The following is a description of a gene set: studied in species Homo sapiens Human Gene Set: TRAVAGLINI_LUNG_CAPILLARY_INTERMEDIATE_2_CELL from publication Travaglini KJ, Nabhan AN, Penland L, Sinha R, Gillich A, Sit RV, Chang S, Conley SD, Mori Y, Seita J, Berry GJ, Shrager JB, Metzger RJ, Kuo CS, Neff N, Weissman IL, Quake SR, Krasnow MA (PMID 33208946), and this is the list of marker genes: DAZAP2, BBLN, PTMS, ATP5PD, CCNI, CCDC25, SERPINB6, GBP3, TMEM219, POMP (NCBI Gene Id 51371), WDR45B, SUMO3, GMFG, RFLNB, RHOA, S100A6, IFI27L2, GPIHBP1, MT1M, GABARAP, CAPN2, SH3BP5, HLA-DQA1, UBA52, S100A10 (S100 calcium binding protein A10), PCNP, SYNJ2BP, PSIP1, RBX1, ARHGEF12, FKBP8, FAM204A, S100A13, FAM107A (family with sequence similarity 107 member A), SSU72, MT1E, CETN2, BAG1, IFI27, JCAD, SAP18, RPL27, AP3S1, NUCB2, UBE2L6, MRFAP1, NHERF2, SERINC1, MAFF, RWDD1, POLR2L, PCAT19, CCL20, ARL2 (ADP ribosylation factor like GTPase 2), IFITM3, NDUFA4, CCDC69, SLC14A1, PDAP1, HLA-DPB1, ARHGAP18, PDLIM2, TMEM126B (NCBI Gene Id 95018), RALA, C7orf50, RGCC, SLU7 (NCBI Gene Id 10569), PAK4, NDUFA13, PTP4A3, NDUFS5, MOCS2, RBM17, TRIR, TLE5, MRPS18B, RPS24, RPL27A, SNX5, FBXO21, PCTP, POLR3GL, R3HCC1, C1orf115, C4orf3, RPLP2, SPOP (NCBI Gene Id 8405), GOLGA4, RPL38, LSM3, ATRX, GIMAP6, ZBTB8OS, NDRG2, CARINH, MT2A (NCBI Gene Id 4502), GPX1, VAMP5, EI24, SET, ANAPC16, SNHG6, KIF1C, NDUFB4, UQCR11, RPS27L, HSBP1, HSPA12B, SH3BGRL, HNRNPM, SUMO2, MTIF3, MBP, TPM1, VAMP3, COX7C, SEC62, KLHL5, YBX1, ARRDC2, IL7R, OPTN, RAP1A, EGFL7, ISCU, HMGB1, SCGB3A1 (NCBI Gene Id 92304), SRP9, RPL37, DPYSL3, AKR1C3, GPX4, CARD16, ZC3H13, TMA7, RPS20, MYL6, FIS1, RPS27A, YWHAE, ZEB1, COX6C, BTN3A1, ATP5IF1, RPS4Y1, FTL, COPS9, RPS28, OST4, IFI6, OTUD6B-AS1, MT1L, ANP32B, POLR2F, SLIRP, SNRPD2, MAP4, MED28, S100A3, NAP1L1, CAVIN1, TTC1, SVIP, CDC26, STXBP6, TPM4, NOSTRIN, PPIA, SEC61G, C1orf54, ARPC1A (NCBI Gene Id 10552), COX17, MRPS18C, BUD31, CYB5A, LHFPL6, MYZAP, UBE2Q2, TAF15, IL32, TPM3, PRX, PRMT1, PLGRKT, ATP2C1, HLA-DQB1, MYH9, TMEM100, LAMTOR1, RCSD1, EMP3, C22orf39, MYLK, ADIRF, PTPRN2, COX7A1, ARPP19, RPS19BP1, HLA-DRA, RPL23, HNRNPA3, EPB41L2, KTN1, HNRNPH3, ADIPOR2, CHMP5, LRCH1, NEDD8, BNIP3, ARL2BP, LARP7, CAPZA2, FCN3 (NCBI Gene Id 8547), SZRD1, RPL22 (NCBI Gene Id 65281), IFITM2, TAGLN (NCBI Gene Id 6876), SPARC, COMMD6, CALR, PPP2R5A, RPL41, NDEL1, TNFSF12, SYF2, UQCRB, TNIP1, FKBP1A, RPL31, TADA3, IK, DYNLT1, RPL34, UBE2E1, TMEM230, CLTB, WASHC2A, HTATIP2, PRDX5, FNBP1L, NGRN, PET100, PTMA, PCGF5, RPL30, BTN3A3, RPS7 (ribosomal protein S7), MPG, NSRP1, DDIT4, UQCRQ, SERF2, PIN4, DCTN1, SNHG32, BAALC, GNG5, LGALS1, TMSB4X, CSTB, RAB13, PINK1, MRPL33, ATP5MK, NAA38, MYL12A, TUSC2, SRSF4, DYNLRB1, TMEM204, CPNE2, CFAP36, SCGB1A1, BRK1, COX7A2, GTF3A, ELOB, FAU, DYNC1LI2, COX6B1, H2AZ2 (NCBI Gene Id 94239), CHMP2A, SELENOW, RPLP1, FKBP5, UACA, GPBP1L1, TCEAL3, RTF2, CARHSP1, ATOX1, CFDP1, SPTBN1, CCDC82, GRK5, RNF115, EEF1A1, EIF4EBP2, APOL3, DBI, SYNPO, TMSB10, PEA15, MXRA7, CMPK1, UBL5, CCND3, ZNF667-AS1, ATP5MJ, NDUFB1, TSR2, DPYSL2, RPS29, VAMP8, PAK2, BLOC1S1, RPL39, MKRN1, RPS11, RNF11, HLA-DQA2, CSDE1, GATA2-AS1, CDC25B, NDUFA12, C9orf78, NDUFA2, HMGN2, RPS25, EPAS1, MAPRE1, TCIM, ATP5ME, TP53TG1, FYTTD1, PSME1, CAVIN2, CALM3, CCND1, SEPTIN7, FTH1, CALM1, ARMCX3, DYNLT3, SH3D19, TRAPPC1, RPL37A, GYPC, SEC14L1, OAZ1, ENSA, GUK1, TPR, PSMB9, PHACTR2, RPL35, UQCR10, TPT1, FOXN3, ERGIC2, ARPC2, HPCAL1, PFDN5, ANP32A, EIF5B, UBE2L3, RPS21, PKIG, PPP1R11, ATP5PF, ANAPC13, ROMO1, ITGB1, WBP11, S100A4, ANP32E, DDAH2, TOMM7, NDUFA3, PSME2, PSMA6, GIMAP4, NDUFB9, MORF4L1 (NCBI Gene Id 10933), RNF181, RPS27, MYL9, HPGD, BCL6B, COX4I1, MMP24OS, SEPTIN2, RPS12, FGD5-AS1, NDUFS6, SH3BGRL3, RPS26, ATP5F1E, RPL36AL, B2M (beta-2-microglobulin), CHCHD7, PSME3IP1, KIF5B, SELENOK, WFDC1